Given this list of marker genes GJA1, INHBB, OPRK1, FOXL2, TACR2, CRH, NPVF, INHA, INHBA, LEP, SMAD4, here is a description of the gene set: studied in species Homo sapiens Any process that modulates the frequency, rate or extent of the regulated release of a gonadotropin. Human Gene Set: GOBP_REGULATION_OF_GONADOTROPIN_SECRETION